Given this list of marker genes MTMR3, RRAGB, GTF2E1, C4BPA (NCBI Gene Id 722), MR1, DNAJC16, GATB, GCN1, NCOA6, CAMTA2, PRUNE1, RCAN1, MED13, MYH6, P2RY10, PRR3, MPV17, GLYAT, TTBK2, JOSD1, GRB10, PAF1, GADD45G, TNFAIP1, SLC6A4, ENO2, METAP2, PYGB, ITGB1 (NCBI Gene Id 3688), ATG12, FMNL1, CYP4F2, MOS, EID1, SEC23B, MAGEA5P, CXADR, PAIP1, MARF1 (NCBI Gene Id 9665), TMEM8B, KCNA1, ATP1A1, FOXE1, MED1, BAG1, ACADVL, TAGLN3, AKT3, PRDM1, PIK3CA, C22orf31 (chromosome 22 open reading frame 31), BAG5, GLIPR1, DHX16, MYL1, CBR4, ST3GAL1, SNCA, UFL1, CCL11, RRM1, DHX38, PLCB1, ZNF623, WDR82, CLDND1, SATB1, BPTF (NCBI Gene Id 348241), PCGF1, TLE4, RAP1B, LRP2, SERINC1, DGKA, KAT7, MYH11, OGT, TSPAN8, ANXA10, SERPINB5, CHAF1A, CORO2A, RAB5A, GLT8D1, RO60, TRAPPC8, PHF1, PLA2G2A, ILF3, STXBP3, RRAD (RRAD, Ras related glycolysis inhibitor and calcium channel regulator), HADHA, OSBP, DOCK4, CLIP2, SRRM2, KEAP1, POLG, FBXO28, ASCC2, CCT4, MST1R, BCL2L11, PROC, SUPT5H, MAN2C1, SLC3A2, BTN1A1, UPK1A, CSF1R, STK10, RYR3, HNRNPU (NCBI Gene Id 3192), DNAJC6, ATP6V0E1, CEP350, TRPM1, PLCL1, CA1, NFATC3, EPM2A, RBPJ, PRCC, VAT1, MTMR7, MITF, PHLDB1, EPB41L2, RNMT, UNC5C, RDH11, DUSP11, RAD54L2, ZBED4, ANKRD17, VCAM1, SNX27, ACADM, TRAK2, SOCS5, NOVA1, TSC22D1, PTPRA (NCBI Gene Id 5786), HTATIP2, RMND5A, SUN1, CPD, GPR31, PRPS1L1, TCP11L1, ZBTB7A, MAPK14, TAF1, CCT6A, APBB3 (NCBI Gene Id 10307), TYRP1, ATP2A3, ARHGAP33, TMSB15A, GPR137B (NCBI Gene Id 7107), RGL2, TERF2IP, NPEPPS (aminopeptidase puromycin sensitive), THBS3, COL4A1, INPP5E, PIGH, FAM168A, S100A13, MTHFS, MCFD2, SUGP1 (SURP and G-patch domain containing 1), PPIG, ABAT, RAB27B, BLCAP, TBC1D8, MRFAP1L1, YIF1A, ATP6V1D, RALA, PTEN (NCBI Gene Id 8037), HFE, ARL4A, LDB3, SPECC1L, CBX5, PDCD6, PRKDC, ZNF292, VWA5A, SNX7, PIK3C2A, PLS1, SLC5A4, MXD4, H1-3, SECISBP2L, PNN, here is a description of the gene set: Human Gene Set: GSE7548_NAIVE_VS_DAY28_PCC_IMMUNIZATION_CD4_TCELL_UP studied in species Homo sapiens Mice were immunized with PCC (pigeon cytochrome c). from publication Fazilleau N, Eisenbraun MD, Malherbe L, Ebright JN, Pogue-Caley RR, McHeyzer-Williams LJ, McHeyzer-Williams MG (PMID 17529982) Genes up-regulated in CD4 T cells from lymph nodes: naïve versus day 28 after immunization.